Given this list of marker genes ABCG5, APOB, PCSK9, LDLR, PRKG1, ABCG8, LDLRAP1, here is a description of the gene set: Enlargement of the diameter (cross-section) of a coronary artery as defined by a focal dilation of a segment at least 1.5 times larger than the reference vessel. Coronary artery aneurysm Human Gene Set: HP_CORONARY_ARTERY_ANEURYSM species: Homo sapiens